The following is a description of a gene set: species: Mus musculus Any process that modulates the frequency, rate or extent of the RIG-I signaling pathway. Mouse Gene Set: GOBP_REGULATION_OF_RIG_I_SIGNALING_PATHWAY, and this is the list of marker genes: Dhx58, Usp17le, Ddx60, Usp15, Rnf125, Zcchc3, Zc3hav1, Nploc4, Ankrd17, Nop53 (NCBI Gene Id 98700), Oasl1, C1qbp, Sec14l1, Nlrx1, Trim15, Pum1, Pum2, Ufd1, Gpatch3